The following is a description of a gene set: Reactome Pathway: ERCC6 (CSB) and EHMT2 (G9a) positively regulate rRNA expression species: Homo sapiens About half of the rRNA genes in the genome are actively expressed, being transcribed by RNA polymerase I. As inferred from mouse, those genes that are expressed are activated by ERCC6 (also known as Cockayne Syndrome protein, CSB) which interacts with TTF-I bound to the T0 terminator region (also know as the Sal Box) of rRNA genes. ERCC6 recruits the histone methyltransferase EHMT2 (also known as G9a) which dimethylates histone H3 at lysine-9 in the coding region of rRNA genes. The dimethylated lysine is bound by CBX3 (also known as Heterochromatic Protein-1gamma, HP1gamma) and increases expression of the rRNA gene. Continuing dimethylation depends on continuing transcription. Mutations in CSB result in dysregulation of RNA polymerase I transcription, which plays a role in the symptoms of Cockayne Syndrome. part of: Positive epigenetic regulation of rRNA expression, and this is the list of marker genes: H2BC12, HDAC2, ERCC6, TTF1, CHD4, H2BC9, H2BC4, H2BC21 (H2B clustered histone 21), EHMT2, H3C15, GATAD2B, CBX3, MTA3, CHD3, H2AJ (NCBI Gene Id 83739), GATAD2A, RBBP7, HDAC1, H2AC14, H3C1, H2AB1, H2AZ2, MBD3, RBBP4, H2BC5, MTA1, H3-3A, H2BC13, H2BC14, H2AC18 (NCBI Gene Id 8337), H2BC1, H2BC12L, H2BC26, H2BC17, H2BC15, H2AC4 (NCBI Gene Id 8335), H4C1, 45S pre-rRNA gene, H2AC6 (H2A clustered histone 6), MTA2, H2BC3, H2AX (NCBI Gene Id 3014), H2AC7, H2BC11, H2AC20 (H2A clustered histone 20)